Given this list of marker genes Twist1, Obp2a, Sctr, Apoh, Daglb, Plin5, Prkce, Acsl5, Prkcd, Akt2, Aadac, Cpt1a, Il1b, Clstn3, Apoa4, Fgf21, Fabp1, Enpp7, Ldlr, Abcd2, Apoc2l, Apoc2 (NCBI Gene Id 11813), Abhd5, Abcd1 (NCBI Gene Id 11666), Mtln, Irs1, Angptl3, Irs2, Pnpla2, Sct, Apoa2, Adora1, Apoa5, here is a description of the gene set: Any process that activates or increases the frequency, rate or extent of the chemical reactions and pathways resulting in the breakdown of lipids. studied in species Mus musculus Mouse Gene Set: GOBP_POSITIVE_REGULATION_OF_LIPID_CATABOLIC_PROCESS